Given this list of marker genes NUP85, AHCTF1, VRK2, TUBB4A, KPNB1, NUP188, VRK1, LMNA, NDC1, TMPO, LMNB1, CHMP2A, NUP133, SUMO1, NUP93, TUBA3C, PPP2R2A, NUP98, CHMP4B, TUBA1B, TUBB4B, TUBB3, SPAST, RAN, VPS4A, NUP155, TUBB1, BANF1, NUP37, TUBA3D, CHMP2B, PPP2R1A, TUBB6, TUBA4A, IST1, CHMP3, TUBA1A (tubulin alpha 1a), LBR, NUP43, TUBB2B, CHMP4C, TUBB8, TNPO1, POM121 (POM121 transmembrane nucleoporin), PPP2CA, TUBB2A, TUBA3E (NCBI Gene Id 150521), ANKLE2, TUBAL3, LEMD2, RCC1 (regulator of chromosome condensation 1), CHMP6, CCNB2, NUP35, NUP54, SEH1L, CC2D1B, LEMD3, EMD, NUP58, SEC13, UBE2I, TUBA4B, TUBA1C, NUP205, NUP62, SIRT2, TUBB8B, RANGAP1, CCNB1, TUBA8, CHMP7, CDK1, NUP160, CHMP4A, NUP107, here is a description of the gene set: studied in species Homo sapiens Human Gene Set: REACTOME_NUCLEAR_ENVELOPE_NE_REASSEMBLY Nuclear Envelope (NE) Reassembly